Given this list of marker genes CASP9, APAF1, TRAP1, PINK1, HTRA2, CASP3, CYCS, here is a description of the gene set: Mutation-inactivated PINK1 to intrinsic apoptotic pathway. Pathway ID: N01048. Pathway type: Variant. Pathway class: nt06463 Parkinson disease. Human Gene Set: KEGG_MEDICUS_VARIANT_MUTATION_INACTIVATED_PINK1_TO_INTRINSIC_APOPTOTIC_PATHWAY_N01048 Pathway Definition from KEGG: PINK1* // (HTRA2,TRAP1) // CYCS == APAF1 -> CASP9 -> CASP3 species: Homo sapiens